The following is a description of a gene set: Human Gene Set: GOMF_METAL_ION_SEQUESTERING_ACTIVITY studied in species Homo sapiens Binding to a metal ion to prevent it from interacting with other partners or to inhibit its localization to the area of the cell or complex where it is active., and this is the list of marker genes: CASQ2, SLC39A4, FTH1, LCN2, MT3 (metallothionein 3), MYT1L, S100A7